The following is a description of a gene set: species: Homo sapiens O-linked glycosylation of mucins Human Gene Set: REACTOME_O_LINKED_GLYCOSYLATION_OF_MUCINS, and this is the list of marker genes: MUC15, MUC21, GALNT7, B3GNTL1, MUC7, CHST4, GALNT14, GALNT4 (polypeptide N-acetylgalactosaminyltransferase 4), GALNT13, GALNT15, A4GNT, MUCL1, B4GALT6, MUC1, ST6GAL1, GCNT1, GALNT3, C1GALT1, ST3GAL1, ST6GALNAC4, MUC5B (mucin 5B, oligomeric mucus/gel-forming), B3GNT6, GALNT11, GALNT1, GALNT9, MUC17, B3GNT5, B4GALT5, ST3GAL4, GALNT6, GALNT10, MUC3A, MUC4, MUC6, C1GALT1C1, GALNT16, GALNTL6, MUC16, GCNT4, MUC20, GALNT18, GALNT17, GALNT2, B3GNT3, ST3GAL2, B3GNT7, MUC5AC, ST6GALNAC2, GALNTL5, GALNT5, GCNT3, B3GNT8, B3GNT2, GALNT12, ST6GALNAC3, B3GNT4, B3GNT9, GCNT7, ST3GAL3, GALNT8, MUC13, MUC12